The following is a description of a gene set: Mouse Gene Set: CUI_TREG_IL33_RESPONSE_UP from publication Cui A, Huang T, Li S, Ma A, Pérez JL, Sander C, Keskin DB, Wu CJ, Fraenkel E, Hacohen N (PMID 38057668) Cytokines mediate cell-cell communication in the immune system and represent important therapeutic targets. A myriad of studies have highlighted their central role in immune function, yet we lack a global view of the cellular responses of each immune cell type to each cytokine. To address this gap, the authors created the Immune Dictionary, a compendium of single-cell transcriptomic profiles of more than 17 immune cell types in response to each of 86 cytokines (>1,400 cytokine-cell type combinations) in mouse lymph nodes in vivo. A cytokine-centric view of the dictionary revealed that most cytokines induce highly cell-type-specific responses. For example, the inflammatory cytokine interleukin-1β induces distinct gene programmes in almost every cell type. A cell-type-centric view of the dictionary identified more than 66 cytokine-driven cellular polarization states across immune cell types, including previously uncharacterized states such as an interleukin-18-induced polyfunctional natural killer cell state. species: Mus musculus Genes positively differentially expressed in cell type: Treg upon treatment with cytokine: IL-33 in mouse lymph nodes in vivo., and this is the list of marker genes: Nop10, Ranbp1, Psmb8, Ifi27l2a, Psma7, Zbp1, Eif5a